Given this list of marker genes Fip1l1, Cpsf1, Cpsf2, Ncbp1, Cstf2, Pabpn1, Cpsf3, Pcf11, Cstf2t, Nudt21, Cpsf6, Cstf3, Papola, Ncbp2, Cpsf7, Clp1, Wdr33, Cpsf4, Sympk, Cstf1, here is a description of the gene set: species: Mus musculus Processing of Intronless Pre-mRNAs Mouse Gene Set: REACTOME_PROCESSING_OF_INTRONLESS_PRE_MRNAS